The following is a description of a gene set: Any process that modulates the frequency, rate or extent of the chemical reactions and pathways resulting in the formation of proteins by the translation of mRNA in a mitochondrion. Human Gene Set: GOBP_REGULATION_OF_MITOCHONDRIAL_TRANSLATION studied in species Homo sapiens, and this is the list of marker genes: DDX3X, TACO1, MTG2, C1QBP, RPUSD3, UQCC2, MPV17L2, LRPPRC, FASTKD3, TRMT10C, TRUB2, MTG1, ALKBH1 (NCBI Gene Id 8846), FASTKD2, MALSU1, MIURF, CDK5RAP1, RMND1, SHMT2, TSFM, NGRN, RCC1L, COA3 (cytochrome c oxidase assembly factor 3), METTL8, NSUN3, RPUSD4